The following is a description of a gene set: species: Homo sapiens Genes down-regulated in comparison of dendritic cells (DC) stimulated with LPS (TLR4 agonist) at 2 h versus DCs stimulated with LPS (TLR4 agonist) at 8 h. from publication Napolitani G, Rinaldi A, Bertoni F, Sallusto F, Lanzavecchia A (PMID 15995707) Toll like receptors (TLRs) sense microbial products and initiate adaptive immune responses by activating dendritic cells (DCs). Since pathogens may contain several agonists we asked whether different TLRs may synergize in DC activation. We report that in human and mouse DC TLR3 or TLR4 potently synergize with TLR7, TLR8 or TLR9 in the induction of selected cytokine genes. Upon synergistic stimulation, IL-12, IL-23 and Delta-4 are induced at levels 50-100 fold higher than those induced by optimal concentrations of single agonists, leading to enhanced and sustained TH1 polarizing capacity. Using microarray analysis we show that only 1.5% of the transcripts induced by single TLR agonists are synergistically regulated by combinations of TLR4 and TLR8 agonists. These results identify a combinatorial code by which DCs discriminate pathogens and provide (suggest) a rationale to design adjuvants for TH1 responses. Series_overall_design: 3 untreated, 3 treated with LPS at 2h, 3 treated with LPS at 8h, 3 treated with R848 at 2h, 3 treated with R848 at 8h, 3 treated with LPS + R848 at 2h, 3 treated with LPS + R848 at 8h Human Gene Set: GSE2706_2H_VS_8H_LPS_STIM_DC_DN, and this is the list of marker genes: ZUP1, MMAA, ADTRP, IGF2BP3, SLC8A1-AS1, ZNF230, ENSG00000229727, CFAP70, RSBN1L, NFAT5, OAS1, PI4K2B, SINHCAF, LINC01141, DEPDC7, LDLRAD3, TNFRSF9, GBP4, MAP3K13, UNC5C, PSMA2, ZNF367, RFTN1, COBLL1, KYNU, CLDN6, CRACD, BLVRA, GUCY1B1, MYH7B, CSRNP2 (NCBI Gene Id 81566), ARHGAP22, PLSCR1, HCFC2, RAD9A, C5orf15, IGSF21, PDE4DIP, DDX60L, MGLL, MT2A (NCBI Gene Id 4502), EPSTI1, CFAP65 (NCBI Gene Id 255101), MS4A14, CYP27B1, CNOT4 (NCBI Gene Id 4850), SLC38A5, JAK3, TRAFD1, AK8, PCGF5 (polycomb group ring finger 5), STAT2, PPM1K, LYSMD2, CNP, GCKR, SLC25A28, PEX13, MAP4K4, SERPINA1, VAC14, SOCS2, HAPLN3, LILRB2, PSME2, EED, APOBEC3G, BHLHE22, CASP7, ITGB8, IL2RA, HLA-F, UBE2Z, NLRC5, OPTN, PSD3, ENSG00000255537, C4orf46, DYNLT1, AIM2, CYRIA, PPP2R2A, ATF5, AFDN, BASP1, DUSP4, MSC-AS1, SSB, FXYD6, KIAA0040, CSF2RA, PLA1A, SFT2D2, LAMB3, TNFSF4 (TNF superfamily member 4), CCNA1, TSPY1, TRIM5, APOBEC3A (apolipoprotein B mRNA editing enzyme catalytic subunit 3A), CEP135, SERPINB9P1, IL15RA, TRIP10, CXCL6, FOXG1, TRIM22, ZBTB32, MT1X, ZNF107, DNAI3, FSD1L, LINC01356, NFKB1, TRIM69, TBX19, SAMD9, LYN, POU6F2, MOV10, EBI3, IFITM1, NCF1C, MAGEA8, PLXNC1, KDM6A, NMI, TBC1D13, SCYL3, C15orf48, TAP2, NUP210L, HLA-G, CFAP161, TTYH2, CD38, NECTIN2, LINC00467, APOL2, DTX3L, JAK2, GRB10, YEATS2, ETV7, LAMP5, CCR7, ALOX15B, TPSG1, TAP1, RDX, PPFIBP2, CALHM3 (NCBI Gene Id 119395), CLEC2D, TMCC3, RAB29, IDO2, DDX60, GUCY1A1, CD48, SYNPO2, FLACC1 (NCBI Gene Id 65070), LINC01181, TUBB2A, CCL5, ANKRD33B, EIF2AK2, DUSP5 (dual specificity phosphatase 5), SP140, ZNF567, TMEM140, RAB30, UBE2L6, LILRA3, PSMA3, C1orf21, TMEM268, LINC00158, PLAC8, RPS6KC1, IFI35, NCK2, NTN1, ZNF281, PRR5L, STX17, LRRFIP2, NUB1, CFB, PPA1, ZNFX1, TIA1, TMEM131, AIDA (NCBI Gene Id 92615), DHX58, SETDB1